Given this list of marker genes MTAP, TGFB1 (NCBI Gene Id 7040), ANO5, CA2, STX16, CSF1R (colony stimulating factor 1 receptor), TNFSF11, GNAS, SOST, here is a description of the gene set: Diaphyseal sclerosis studied in species Homo sapiens Human Gene Set: HP_DIAPHYSEAL_SCLEROSIS An elevation in bone density in one or more diaphyses. Sclerosis is normally detected on a radiograph as an area of increased opacity.